Given this list of marker genes Slamf8, Rab7, Rab38, Slc4a7, Tcirg1, Rab39, Rab20, here is a description of the gene set: Mouse Gene Set: GOBP_PHAGOSOME_ACIDIFICATION studied in species Mus musculus Any process that reduces the pH of the phagosome, measured by the concentration of the hydrogen ion.